The following is a description of a gene set: Human Gene Set: GOMF_MHC_CLASS_I_PROTEIN_BINDING species: Homo sapiens Binding to a major histocompatibility complex class I molecule; a set of molecules displayed on cell surfaces that are responsible for lymphocyte recognition and antigen presentation., and this is the list of marker genes: VCP, KLRC4-KLRK1, DERL1, CD244, ATP5F1B, ATP5F1A, LILRB1, PILRA, CD8B, KLRK1 (killer cell lectin like receptor K1), TAPBP, CD8B2, BCAP31, TAP1, CD8A, TUBB4B, TUBB, LILRB2, PILRB, HLA-E